The following is a description of a gene set: Human Gene Set: GOBP_MITOCHONDRIAL_CALCIUM_ION_HOMEOSTASIS species: Homo sapiens Any process involved in the maintenance of an internal steady state of calcium ions within the cytoplasm of a cell or between mitochondria and their surroundings., and this is the list of marker genes: MCU, SLC25A23, BNIP3, FATE1, MAIP1, PDZD8 (NCBI Gene Id 118987), C19orf12, MCUB, ATP2A1, SLC25A27, LETM1, IMMT, SLC8B1, SLC8A3, LETMD1, MICU3, DISC1, SMDT1, MICU2, AFG3L2, ANXA6, MICU1, RAP1GDS1, MCUR1 (mitochondrial calcium uniporter regulator 1), TGM2